Given this list of marker genes Gng10, Gnb5, Pak1 (NCBI Gene Id 18482), Gng5, Gng2, Akt1, Pik3r6 (NCBI Gene Id 432574), Pik3r5, Gngt2, Rhoa, Gngt1, Gng13, Btk, Pik3cg, Plcb3, Gnb4, Gng3, Gng7, Cdc42, Plcb2, Arhgef6, Gng12, Akt2, Pdpk1, Gnb3, Gng8, Akt3, Gng4, Gng11, Gnb2, Plcb1, Gnb1, here is a description of the gene set: G-protein beta:gamma signalling studied in species Mus musculus Mouse Gene Set: REACTOME_G_PROTEIN_BETA_GAMMA_SIGNALLING